The following is a description of a gene set: studied in species Mus musculus Mouse Gene Set: GOBP_NEURON_RECOGNITION The process in which a neuronal cell in a multicellular organism interprets its surroundings., and this is the list of marker genes: Crtac1, Diaph1, Bsg, Robo1, Casp6, Tnfrsf21, Nrcam, Gap43, Myot, Ext1, Ephb2, Rtn4, Nrp1, Prtg, Casp3, Sema5a, Cntn6, Epha3, Robo2, Ptprz1, Wnt5a, Plxnd1, Bdnf, Arhgap35, Foxg1, Cdk5r1, Nptn, Dscaml1, Megf8, Ndn, Mypn, L1cam, Epha4, Amigo1, App, Cntn5, Nexn, Fezf2, Celsr3, Sema3a, Ncam2, Tnn (tenascin N), Dscam, Efnb3, Ephb3, Diaph2, Emb, Cntnap2, Ywhaz, Ncam1, Cntn2 (contactin 2), Cnr1, Robo3